The following is a description of a gene set: The process in which the anatomical structures of an epithelial sheet are generated and organized. An epithelial sheet is a flat surface consisting of closely packed epithelial cells. Human Gene Set: GOBP_MORPHOGENESIS_OF_AN_EPITHELIAL_SHEET studied in species Homo sapiens, and this is the list of marker genes: DVL1, MMP12, FLNA, FERMT2, RHOA, JAG1, ARHGAP12, HOXB2, LAMA1, SRF, HOXB4, SOX11, PDCD10, BMP7, MSX2, ARHGAP24, ACVRL1, MIR221, LIN7C, BMP5, PALS1, VANGL2, ITGAV, CEACAM1, PLET1, COL5A1, NOTCH2, PHLDB2, ITGB1, CLASP2, RREB1, WNT5A, SOS1, PTEN, TOR1A, RHOC, ITGB3, FERMT1, MRTFA, TMEFF2, ADAM17, MEGF8, NOTCH1, CD44, PHACTR4, TBX20, PDPN, LCP1, DVL2, DLL4, ITGA5, ARHGAP35, DAG1, FLRT3, LRG1, HBEGF, FIGNL2, CLASP1, WNT7A, CD151, AJUBA, CARMIL2, MTOR, HTN1, ITGB5, DDR1